Given this list of marker genes Akt1s1, Casp9, Cdkn1a, Cdkn1b, here is a description of the gene set: Reactome Pathway: AKT phosphorylates targets in the cytosol This event has been computationally inferred from an event that has been demonstrated in another species.<p>The inference is based on the homology mapping from PANTHER. Briefly, reactions for which all involved PhysicalEntities (in input, output and catalyst) have a mapped orthologue/paralogue (for complexes at least 75% of components must have a mapping) are inferred to the other species. studied in species Mus musculus electronically inferred by orthology from the curated human pathway part of: PIP3 activates AKT signaling